Given this list of marker genes TAF1, LMNA, ADH1C, TK2, GBA1, POLG, LRRK2, ATXN3, VAPB, PRKN, VPS35, NR4A2, DNAJC13, SGCD, L1CAM, ATXN8OS, PRKAR1B, SYNJ1, TIMM8A, MECP2, PTRHD1, EIF4G1, ZMPSTE24, KDM5C, PODXL, TMEM106B, SNCA, RAB39B, NAA10, DNAJC6, CSF1R, COL2A1, TBP, MT-TT, TRPV4, SNCAIP, GIGYF2, MAPT, FBXO7, DCTN1, SLC18A2, ATXN2, here is a description of the gene set: Shuffling gait studied in species Homo sapiens A type of gait (walking) characterized by by dragging one's feet along or without lifting the feet fully from the ground. Human Gene Set: HP_SHUFFLING_GAIT